The following is a description of a gene set: Human Gene Set: GOBP_FRUCTOSE_TRANSMEMBRANE_TRANSPORT The directed movement of fructose into, out of or within a cell, or between cells, by means of some agent such as a transporter or pore. Fructose exists in a open chain form or as a ring compound. D-fructose is the sweetest of the sugars and is found free in a large number of fruits and honey. species: Homo sapiens, and this is the list of marker genes: SLC2A11, SLC2A5, SLC2A3, SLC2A9, SLC2A6, SLC2A8, SLC2A2, SLC2A7, SLC26A5, SLC5A10